Given this list of marker genes Bax, Mcl1, Bak1, Smad3, Gper1, Igf1, Bcl2, Fzd9, Nol3, Mapk9, Bbc3, Pla2g6, Timm50, Parl (presenilin associated, rhomboid-like), Cck, Fis1, Bcl2a1c, Sfn, Mmp9, Akt1, Bad, Pink1, Ggct, Gpx1, Bnip3, Mfn2, Pycard, Fas, Wdr35, Ppif, Bid, Bcl2l1, Atp7a, Lmna, Tnfsf10 (tumor necrosis factor (ligand) superfamily, member 10), Bik, Hrk, Ghitm, Moap1, Mllt11, Bmf, Avp, Pdcd5, Bcl2l10, Higd1a, Bcl2a1d, Plscr3, Hgf, Triap1, Fxn, Plaur, Jun, Bcl2a1a, Fam162a, Bcl2a1b, Trp53, Prkn, Bcl2l2, Opa1, Psmd10, Pdcd5-ps, Mff, Bcl2l11, Arrb2, Pmaip1, Dnm1l, Sod2, Bok, Prelid1, here is a description of the gene set: Mouse Gene Set: GOBP_RELEASE_OF_CYTOCHROME_C_FROM_MITOCHONDRIA species: Mus musculus The process that results in the movement of cytochrome c from the mitochondrial intermembrane space into the cytosol, which is part of the apoptotic signaling pathway and leads to caspase activation.